Given this list of marker genes TENM4, DOLK, DYNC1I1, EIF3J, LDB2, ANXA4, SCML1, ATP13A3, PLGRKT, MANSC1, FKBP1B, ILK, PARVB, CYB5R3, ATXN8OS, SSR4, CHPF2, MCTP2, ATXN1, EEF1E1, MAGI1, SERPINB13, HIGD1A, TPMT, LAMP2, PARK7, CEP15, ARID5B, RAC1, STAT1, CCND2, MTMR11, LAMTOR5, RIDA, CDH2, IFITM2, P4HB, IPO7, BEX1, FAM216A, RTCA, IFT81, XKR8 (XK related 8), GRHPR, FEZ2, PKN2, GOLGA8A, TRIM2, TBK1, DENND5B, FTO, PPP1R14B, CAMK2N1, FGF13, SASH1, SERP1, AAMP, ZMYND11, SIDT2, DENND5A, TMEM184B, CTTN, HACD3, GGH, REXO2 (RNA exonuclease 2), TMX1, NHLRC2, LGALS3BP, TMEM184C, CHD5 (NCBI Gene Id 26139), MAMLD1, KATNBL1, MTARC2, RGS13, COPS2, NAGA, DNAJC15, TIMP3, RPS18 (NCBI Gene Id 6222), SRPRB, P3H1, TRAF3, RHOBTB3, LRP4, FZD3, YIF1A, MGST3, BAG2, USP13, OGFOD1, PCCA, TRIM49, NDEL1, HLA-F-AS1, FAM171A1, RXRA, MLF1, CNN2, MTX2, ELOVL6, MORF4L2, POLR2L, IMPDH1, SACS, CD302, ZNF112, DDR2, CTSK, TRIM16, STAG3L4, FUCA1, UEVLD, ZCCHC24, APOO, HSPA4L, UBE2E1, AIMP1, EPHB4, BCL2L2 (BCL2 like 2), CNN3, SMAD3, OSMR, PFKM, GLIPR1, SMNDC1, B4GALT1, CSRP2, ARMC9, MYO5A, KLF8, RAN, ATP10D, RTL8A, ABCE1, ZZZ3, ATF3, FOXO1, FKBP10, GNB2, BBIP1, SMIM7, SLC19A2 (NCBI Gene Id 7826), PREX2, LDOC1, TMA16, ZC3H12A, SLC31A1, SLC35F2, CHPT1, EOGT, RTL8C, NTM, LACTB2, ST13, LARGE1, DYNC1H1, UQCR11, RRBP1, SNTB2, CREG1, BAALC (BAALC binder of MAP3K1 and KLF4), ARSB, ZNF516, CEP170, DNAJC13, BMAL2, DNAJC12, EMILIN1, ZCCHC2, SLC22A4, PSMA7, MYEF2, CAMSAP2, CNTLN, NTAQ1, MACF1, ASAH1, CASP1, IFT46, HYI, KLF9 (KLF transcription factor 9), LMNA, CHST15, OTC, PYGL, RPL27A, PDGFA, NEK1, SEC23B, DPY19L1, TEAD3, ATP9A, KANK2, MYO1D, MEST, NARS1, KCNK1, NBN, DNAJC6, NDUFA1, here is a description of the gene set: species: Homo sapiens Genes down-regulated in comparison of CD4 CD8 thymocytes versus thymic stromal cells. Subpopulations of human fetal thymocyte and circulating naïve T cells were obtained through FACS sorting, including CD3-CD4+CD8- intrathymic T progenitor cells (ITTP), CD3intCD4+CD8+ \double positive\ thymocytes (DP), CD3highCD4+CD8- \single positive\ thymocytes (SP4), CD3+CD4+CD8-CD45RA+CD62L+ naive T cells from cord blood (CB4+), and CD3+CD4+CD8-CD45RA+CD62L+ naive T cells from adult blood (AB4+). from publication Lee MS, Hanspers K, Barker CS, Korn AP, McCune JM (PMID 15210650) Human Gene Set: GSE1460_DP_THYMOCYTE_VS_THYMIC_STROMAL_CELL_DN